Given this list of marker genes MYO1H (NCBI Gene Id 732239, myosin IH), KCNJ2 (NCBI Gene Id 3759), USP18, TRPM4, DUOXA2, SFTPC, TMEM43 (NCBI Gene Id 79188), PPA2, TSPYL1, CALM2, SCN4B, CAVIN1, KCNE2, NDUFA8, MPV17, TANGO2, TRDN, SLC25A20, PROP1, ANK2, CRELD1, HCN4, SCO2, CASQ2, KCNE1, ASXL1, POU1F1, LAMB3, ACY1, SFTPB (NCBI Gene Id 6439), LHX3, MYL4, PRKAG2, HTRA2, TSHR, TG, GLYCTK, IFNG, LAMC2, HESX1, HEPHL1 (hephaestin like 1), KCNJ5, GFM2, DUOX2, TLL1, TBX5, SCN4A, DST, TPO, SNTA1, NPPA, COQ4, CALM1, MMACHC, COQ9, NDUFA2, PAX8, GLUL, TNNT2, ABCA3, GBE1, DOLK, CACNA2D1, MTO1, UQCRFS1, GNB5, SCN9A, AKAP9 (A-kinase anchoring protein 9), CACNA1D, SLC4A3, GNB2 (G protein subunit beta 2), BVES, LIPT1, CACNA1C, PRDX1, ACTA1, TWNK, GRIN1, KCNA5, EFEMP2, LAMA3, NOS1AP, IYD, LMNA, SCO1, SCN10A, SCN5A, TSC2, CAV3, CALM3, DES, KCNH2, ECHS1, BRAT1, TSHB, SLC5A5, SGO1, TNNI3K, KCNQ1, LHX4, here is a description of the gene set: A slower than normal heart rate (in adults, slower than 60 beats per minute). Human Gene Set: HP_BRADYCARDIA Bradycardia species: Homo sapiens